Given this list of marker genes ZNF711, FBN2, SPOPL, IVNS1ABP, UBL3, RIN2, BRD10, DMRT2, NDEL1, KLF12, TMSB4X, YTHDC1, LRRC37A11P, ARMH4, STRBP, STX6, NR4A2, PSMF1, TAF1D, EIF4A2, FNDC3B, ESCO1, GDI2, NEUROD1, DLGAP2, RTF1, ATP1B1, ELOVL4, NOVA1, MAPK1, MAPK8IP1, ADAMTS5, SEPTIN4, TACC1, GRIK2 (NCBI Gene Id 2898), ADGRB3, MIOS, SLC31A1, POLG, HNRNPA2B1, CHN2, YAF2, ATP6V1A, CUL5, BCL11A, RAP2C, SENP7, STX1A, TACC2, KCNA3, APPBP2, EHMT1, EZH2, FBXW11, GPM6A, LINC00052, MTPN, CAPN3, MAMDC2, MIER3, FBXO11, KRAS, LUC7L3, KCNH5, RBM38, ATP11C, NFIA, SLC38A2, SIRT1, TBC1D15, TLK2, YWHAG, DACH1, SLITRK3, PALM2AKAP2, NIPBL, EP400P1, RBM39, STT3A, DYNC1LI2, SENP5, RICTOR, GREB1L, WAPL, ACVR2A, LRRC37A6P (leucine rich repeat containing 37 member A6, pseudogene), STAG2, PAQR3, PPM1D, TM9SF3, FAF2, MYEF2, SOX11, HIVEP3, MAF, KCTD9, GATAD2B, MSN, PCNA (proliferating cell nuclear antigen), PDS5B, RBFOX1, HNRNPUL1, ST18, VAT1L, STAT5B, SLC39A10, TMTC4, OGT, RBSN, PCDH17, DYRK1A, ARK2N, FN1, ZCCHC2, here is a description of the gene set: Human Gene Set: ATGCAGT_MIR217 species: Homo sapiens Genes having at least one occurence of the motif ATGCAGT in their 3' untranslated region. The motif represents putative target (that is, seed match) of human mature miRNA hsa-miR-217 (v7.1 miRBase).